The following is a description of a gene set: Mouse Gene Set: GOBP_T_HELPER_2_CELL_CYTOKINE_PRODUCTION Any process that contributes to cytokine production by a T-helper 2 cell. species: Mus musculus, and this is the list of marker genes: Stard7, Nlrp3, Cd81, Prkcz, Il31ra, Gba1, Rsad2 (radical S-adenosyl methionine domain containing 2), Il25, Dennd1b, Fosl2, Il6, Crlf2, Xcl1, Arg1, Tbx21, Ifnb1, Gata3, Il4